Given this list of marker genes Defb21, Dmbt1, Adgrb1, Cd14, Bpifa2, Ear10, Gbp2b, F2, Rnase2a (NCBI Gene Id 93726), Zranb2, Psma1, Lbp, Drosha, Ear6, Hspd1, Ninj1, Psmb4, Tlr2, Defb42, Ptafr (NCBI Gene Id 636551), Cd6, Rnase2b, Tril, H2bc21, P2rx7, Defb34, Bpi, Trem3, Selp, Ear14, Camp, Nlrp6, Ear1, Sftpd, Casp4, Nr4a1, Spon2, Hmgb1, Defb15, Scarb1, Ly96, Gbp2, Ear2, Tlr4, Defb19, Trem2, Ltf, here is a description of the gene set: Mouse Gene Set: GOMF_LIPOPOLYSACCHARIDE_BINDING Binding to a lipopolysaccharide. studied in species Mus musculus